The following is a description of a gene set: Genes predicted to be targets of miRBase v22 microRNA hsa-miR-6847-3p in miRDB v6.0 with MirTarget v4 prediction scores > 80 (high confidence targets). species: Homo sapiens Human Gene Set: MIR6847_3P from publication Chen Y, Wang X (PMID 31504780), and this is the list of marker genes: EPB41L1, GRM8, CKS2, CHST11, HIP1R, ANO6, ZNF174, SAXO2, SLC44A5, FEZ2, CDH4, KDM2B, ADARB1, TAB2, TECRL, KBTBD2, EPC2, PHF20L1, ZNF195, PATE4, PAICS, NCOA4 (nuclear receptor coactivator 4), GNAS, TMEM43, CPNE8, HRH2, LSM14A, ARID2, SPA17, C1QTNF3, PTPN14, PATJ, VASH2, PPM1L, FAM24B, SGCE, PSPC1, RANBP10, KCTD1, LATS2, FAM24A, CNOT2, BROX, PPP3CB, UBE2N, SMIM14, FUT9, LIMK1 (NCBI Gene Id 3984), KCNK15, MTM1, PCDH15, ZNF268, ADAM9, CNEP1R1, ARMCX4, SLAMF7 (SLAM family member 7), NFASC, RGS7